Given this list of marker genes ZMIZ1-AS1, MED12, CASC16, SERINC1, KIF1B, ADAT3, NFE2L2, TRIO, JAKMIP2, TDP2, MAMLD1, G3BP1, MSC-AS1, CCRL2, TM2D2, FNIP2, PNPLA8, ITGA5, ASPH, HMGCS1, MMP19, ZNF232, VCP (NCBI Gene Id 94731), TINF2, RRAGC, KLHL9, KCNN4, TRIM28, SP4, TMEM138, SLC26A2, TXNRD1, CD82, DCBLD1, ARHGAP31, SERPINB8, HAS1, YIPF6, ALCAM, TTLL4, MOB3C, ZNF140, PJA1, PIK3R5, SLC35F5, ZNF189, CCR5, ZFYVE1, HSPA8, VPS50, NIBAN1, DNAJA1, GSR, IPO9, STIP1, GTF2A1, GSTO1, ZNF207, MRPL20-AS1, WDR83, IL1A, TRAF3, DYNLL1, C3, STARD3NL, MFAP1, BTBD7, UBE2A, KPNB1, ZC3H12C, IGF2R, MCEMP1, UST, CTNS, RIT1, PSEN1, HIPK2, BET1, ADAM17, CREG1, IRAK2, CYBA, CEMIP2, SLC41A2, NABP1, LRP10, ZFP3 (NCBI Gene Id 7537), AMPD3, ITPRIPL2 (ITPRIP like 2), KDELR2, NFKB1, KLHL28 (kelch like family member 28), SRP54, ABCC1, TANK, MSMO1, STX3, MYO1B, DAB2, CD58, ZNFX1, IL3RA, EWSR1, CES1, ZNF100, RNF145, PPP1R10, ARFGAP3, ARCN1, TMCO3, ASB1, PDGFA, LINS1, SPINK1, PRDM6, MMUT, EYA3, SPRED2, FTH1, LACTB, LGMN, OSGIN2, ST3GAL2, HIP1, MFSD2A, MED13, WDR1, HSP90AB1, ANAPC7, DNAJB6, TSC22D1, ATP6V0E1, CCL7, FLVCR2, CHST7, SERPINE2, TGS1, IER3, CSRNP2, PIR, PDXK, CD22, POLR2A, ZNF230, CDH7, CD2BP2, CLN5, PLEKHB2, RPP14, NPC1, SDC4, SNX9, TUBB6, IL1B, KYNU, GARIN3, HPD, CRNKL1, KMO, ZSCAN32, SZRD1, PSMD1, ABHD4, ZNF701, ELL2, NUP62, SQOR, SLC1A3, WSB2, PLA2G7, SLC5A3, COCH, LAMTOR3, RNF185, TMEM51, CD81, ZNF200, HHIPL2, MRPS6, BTG3, CD63 (CD63 molecule), RAB13, MIR101-1, MCOLN1, TSG101, ATL1 (atlastin GTPase 1), CYP51A1, SC5D (sterol-C5-desaturase), STAM2, RRAGD, GLA, AKR1B1, PDCD6IP, PSMA3, HPS5, TPST1, SEC61B, CRYGS, here is a description of the gene set: species: Homo sapiens Human Gene Set: GSE2770_TGFB_AND_IL4_VS_IL4_TREATED_ACT_CD4_TCELL_48H_UP Th1 and Th2 cells arise from a common precursor cell in response to triggering through the TCR and cytokine receptors for IL-12 or IL-4. This leads to activation of complex signaling pathways, which are not known in detail. Disturbances in the balance between type 1 and type 2 responses can lead to certain immune-mediated diseases. Thus, it is important to understand how Th1 and Th2 cells are generated. To clarify the mechanisms as to how IL-12 and IL-4 induce Th1 and Th2 differentiation and how TGF-beta can inhibit this process, we have used oligonucleotide arrays to examine the early polarization of Th1 and Th2 cells in the presence and absence of TGF-beta after 0, 2, 6 and 48 hours of polarization. from publication Lund R, Aittokallio T, Nevalainen O, Lahesmaa R (PMID 14607935) Genes up-regulated in CD4 T cells activated by anti-CD3 and anti-CD28: TGFB1 and IL4 (48h) versus IL4 (48h).